The following is a description of a gene set: Binding to a phosphorylated protein. species: Mus musculus Mouse Gene Set: GOMF_PHOSPHOPROTEIN_BINDING, and this is the list of marker genes: Trpv1, Socs3, Pcif1 (phosphorylated CTD interacting factor 1), Ms4a2, Stap1, Src, Pde3b, Grb10, Bbs1, Fbxw7, Shc3, Tox3 (NCBI Gene Id 244579), Mapk1, Cd44, Rraga, Plat (plasminogen activator, tissue), Epb41 (erythrocyte membrane protein band 4.1), Irs1, Syk, Yes1, Snca, Fgr, Ubash3b, Aptx, Crkl, Lrp11, Cblb, Sag, Pin1, Shd, Rasa1, Ptpn11, Nedd4, Hck, Mapk3, Rb1, Uri1, Crk, Shb (src homology 2 domain-containing transforming protein B), Shc1, Abl2, Ywhae, Vav1 (vav 1 oncogene), Abl1, Zap70, Ldlrap1, Pik3r2, Sla, Rtf1, Dpysl3, Sirpa, Plcg1, Ptpn6, Samsn1, Tbl2, Cblc, Sh2d3c, Cbx4, Grap, Pik3r3, Dpysl4, Mid1, Grap2, Ywhab, Pfn1, Cbl, Phf6, Sh3bp2, Dpys, Cacnb2, Lyn, Csnk1a1, Crmp1, Cav2, Ywhaz, Grb2, Nck2, Igf2r, Pih1d1, Pin1rt1, Mid2 (NCBI Gene Id 23947), Sfn, Scaf4, Ptpn5, Pik3r1 (NCBI Gene Id 328326), Tbk1, Bcar3 (NCBI Gene Id 99553), Thrap3, Gprin1, Fkbp4, Plcg2, Pafah1b1, Nos1, Acp2, Pitx2, Btrc, Lck, Mtor, Sh2d1b1, Ptpn3 (NCBI Gene Id 545622), Vav2, Arr3, Leo1, Pkd2, Grb14, Men1, She, Arrb1, Scaf8, Prkcsh, Cacnb1